Given this list of marker genes WNT7A, EXOC6B, RIPPLY2, TMEM94, KDM6A, SHOX, SH3PXD2B, NLRP1, MYOD1 (NCBI Gene Id 4654), YWHAE, FLVCR2, KCNAB2, SLC26A2, EDEM3, HABP2, PLXNA1, RPS20, CLP1, ENPP1, HUWE1 (HECT, UBA and WWE domain containing E3 ubiquitin protein ligase 1), POLR3A, DHPS, MYH3, CTNND2, TRAPPC9, MAN1B1, TRAF3 (NCBI Gene Id 7187), PIGG, MUSK, CSGALNACT1, KCNJ8, PEX12, PSAT1, CHD7, TOGARAM1, NKX2-1, WDPCP, PPP1CB, SQSTM1, TCOF1, SIX1, DOK7, OBSL1, ANO3, SOS1, PEX26, GATA4, CHRNG, NFIX, TUBB, ZMPSTE24, CREBBP, ATP1A2, CHRND, RPS26, ROBO3, SEMA5A, PALB2, ATP6V1A, IFT74, HDAC8, CFAP418, PTPN6, BBS1, ACTB, ERMARD, GALNS, ANTXR2, TREM2, NELFA, RPL10, MAPT, SGCE, ESAM, PGAP2, SLC25A24, SNRPB, IMPDH2, PTPN22, HPCA, BCOR, MYL11, SUPT16H, THAP1, LETM1, CDH2 (NCBI Gene Id 1000), MSL3, MCTP2 (NCBI Gene Id 55784), TBCK, HNF1B, SCLT1, GDAP2, PIGV, CHRNA1, TGM6 (NCBI Gene Id 343641), DHCR7, SCN2A, RPL35A, RASA2, BUB1B, SPG11, ERCC1, NF1, FBLN5, PUF60, RREB1, ADAT3, ATP7A (NCBI Gene Id 613259), IDH1, SELENON, FZD2, CCDC8, TUBB3, UBE4B, TGFB2, FILIP1, ZNF699, STX16, PLXND1, BMPER, ADA2, CYP27A1, B3GALT6, PCDH19, PSENEN, TUBA1A, DONSON, HIRA, BAP1, SMARCD1, HDAC4, FOXP2, ODC1, KIAA0586, SMARCAL1, ALDH18A1, SPTLC1, SMARCA2, ARHGEF2, BUB3, WNT5A, ALS2, DDX3X, TNNT3, RAB33B, MRPS22, SCN1A, TLR3, AFF3, RYR1, BPTF, ATN1, HEATR3, NAA10, PRMT7 (protein arginine methyltransferase 7), ARSL, GPKOW, MEOX1, IFT43, IGF1R, TUBB4A, KLHL41, RPS24, THPO, LRPPRC, BBS4, RAPSN, CHN1, FANCI, JMJD1C, SMC1A, FLNA, NDUFB10, COG5, ACVR1, ITPR1, AIFM1, ABCC9, COL6A2, UBE2A, TMEM106B, INTU, NAXE, CDK5, RB1 (NCBI Gene Id 92728), CDC42BPB, IL6ST, H4C5, GABRA3, MAP2K1, NUP188, POGZ, PHOX2A, CFL2, PPARG, RIPK4, FTO, SLC39A13, RAB3GAP1, TPM2, GNPTG, LIPE, VPS11, AHDC1, HRAS, MRAS, MKS1, VPS16, MYF5, B3GLCT, ZMYM2, PIGW, SCNM1, RFX7, SPTBN1, BCR, MAPRE2, WAC, NR4A2, MGAT2, GRN, LAMA5, FOXE1, BBIP1, ATRX, SMS, NAA80, TRPV4, TAF1, AEBP1, NEK9, CRLF1, RAF1, TMCO1, TICAM1, ADARB1, SYNGAP1, RAB5IF, RIT1, TWIST1, PHGDH, OTUD6B, NXN (nucleoredoxin), CCN6, CEP290, GP1BB, SMC3, PIGA, DOCK11, POLR1D, DVL1 (NCBI Gene Id 348497), GABRG2, STAG1, TBX5, PIGS, PTPN11, POP1, IGF1, BBS10, POLE, PNKD, RFT1, SNRPN, GNS, FGFR2, BRF1, FBN2, ALDOA, TASP1, RPL15, GABRA1, KNSTRN, WDR37, PDPN, RNU4-2, COL25A1, COL11A2, RAB3GAP2, ALG8, MAN2B1, TBL1XR1, WDR81, SMAD4, PEX6, MMP23B (matrix metallopeptidase 23B), KCNN3, SHOC2, OTUD5, NRAS, RAB23, SLC35A1, PIGO, CANT1, IFT140, BLTP1, MECP2, DCC, RPS28, MYT1L, SPEN (NCBI Gene Id 348488), CLDN11, KCNN2, GNPNAT1, PEX14, PAICS, TRMT10A, CEP55, TAPT1, SF3B2, SCN4A, ACAN, NALCN, ERCC5, PGAP1, PEX16, FANCL, TMEM260, RPS17 (NCBI Gene Id 6218), CNP, PTCH2, GLE1, B4GALT1, PEX13, MRPS28, GJA5, SUFU, CD96, RPL26, AKT1, MEGF8, DRD2, TOR1A, HS2ST1, CCDC22, KMT2B, GLI2, FGFRL1, PIK3CD, PAM16, C2CD3, POLR1C, RMRP, NOTCH3, ATP6V1E1, IRF3, TBX15, PGAP3, ERCC2, SPRED2, FGFR1, DPYD, PIGY, GNE, COG8, BBS5, TBC1D24, NDUFS3 (NCBI Gene Id 4722), FOXC2, SKI, TIMM50, RFC2, EPHB4, GNAL, HPDL, PROP1, CEP57, WWOX, CEP19, KCTD17, HYLS1 (NCBI Gene Id 50957), SOS2, RNU4ATAC, ALG12 (ALG12 alpha-1,6-mannosyltransferase), INPPL1, MEFV, AGPAT2, KCNH1, GATA1, MRPS16, ECEL1, PLAAT3, DDRGK1, PEX10, CASZ1, BBS12, KAT6A, SATB2, HK1, EIF4H, ERCC6, RPL18, LZTFL1, GPX4, EP300, GTF2IRD1, FAM20C, BBS2, CAV1, IDUA, ANKRD11, DLK1, PRDM16, PHLDB1, NBAS, LUZP1, MADD, APC, RPL9, DDC, RRAS, CACNA1A, PEX1, TRAPPC2, PIEZO1, NCF1, SRY, RPS7, LMX1B, NKX3-2, NOG, PCGF2, COL6A1, ESCO2, STXBP1, SCYL2, MAP3K7, LBR, RRAS2, CSPP1, DPYSL5, WASHC5, TRAF7, DVL3, HNRNPK, CAVIN1, BUD23 (BUD23 rRNA methyltransferase and ribosome maturation factor), TRIP11 (NCBI Gene Id 9321), LMOD3, RTL1, NKX6-2 (NCBI Gene Id 84504), FUS, EMD, KMT2A, TSPOAP1, TALDO1, GRIK2, HES7, COG1, TAF6 (TATA-box binding protein associated factor 6), TTN, MPL, TBK1, SEC24C, PEX11B, MYO18B, NOTCH2, LMNA, ASCC3, COX20, MBD5, UNC93B1, RAP1B, TMEM151A, FBXW11, SETBP1, AMMECR1, PIGN, TRPM3, TRIM32, PAFAH1B1, ATP13A2, FGFR3, BRD4, NBN, KIF7, RPS10, ATP6V0A2, DLL3, PSEN1, CDK13, SIN3A, CDH11, CEP85L, TBX2 (NCBI Gene Id 6909), PRKAR1B, CIZ1 (NCBI Gene Id 25792), VAC14, PIGL, RPL35, METTL27, BBS9, CPLX1, WBP11, HBA2, TECPR2, PPP1R15B, SRCAP, TSR2, HSPG2, XYLT1, SALL4 (spalt like transcription factor 4), COL2A1, DYM, EYA1, CTBP1, TBX6, KDM4B, SDCCAG8, GABRD, SEMA3E, SPRED1, MAFB, RPS19, WDR35 (WD repeat domain 35), BRAF, TBP, VPS33A, LZTR1, NIPBL, GPC6, SIX5, SMPD4, SOX9, SCAPER, VPS13D, DNAJC30, HNRNPR, ALDH1A2, NEB, VCP, RPL11, COL11A1, H3-3A, B3GAT3 (NCBI Gene Id 26229), PKDCC, NUP88, SLC35D1, AMER1, XYLT2, DHX37, PRKCZ, INTS1 (NCBI Gene Id 392616), FN1, SLC18A3, ARL6, HESX1, IRX5, PHF8 (PHD finger protein 8), ACTG1, TCTN2, MRPL12, FIG4, VPS35L, FANCB, SLC31A1, RDH11, TRIP13, CUL7, HECTD4, FKBP6, ATP1A3, MED13L, COG7, ITGA7, GLB1, CP, BAZ1B (NCBI Gene Id 9031), SCN9A, USB1, CTCF, RSPRY1, COMT, CBL, EBP, UNC80, CHMP2B, CRKL, EFNB1, GCH1, RPS15A, RPL8, SOX10, FOS, PEX3, ALG9, WNT4, TMEM270 (transmembrane protein 270), ZFX, COL12A1, RAD21, COL6A3, PIK3CA, LHX4, GPC4, FGD1, RPL27, MAGEL2, MAPK1, ERLIN2, STX1A (syntaxin 1A), SLC2A1 (NCBI Gene Id 6513), TBX1, ERI1 (exoribonuclease 1), FAS (Fas cell surface death receptor), ACTA1, NDE1, TXNDC15, HSPA9, FLI1, EXOSC9, IGBP1, SEPTIN9, UFD1, ABCC6, GPC3, GNPTAB, HERC1, ARVCF, RPL5, TTC8, ZNF142, DHCR24, MICU1, SCP2, MED12 (NCBI Gene Id 9968), KCNC3, POFUT1, TBL2, MEG3, TBR1, ROR2, SVIL, KIF26A, ZC4H2, PIK3C2A, MESP2, DKK1, PEPD, FREM2, LFNG, FLNB, VPS37D, VPS51, GNAS, POU1F1, FHL1, MAB21L1, LIMK1, DDR2, GDF6, BSCL2, CDC42 (cell division cycle 42), PEX2, LHX3, POGLUT1, CDK10, FOXF1, GATA2, SCN1B, SIGMAR1, KRT5, GTF2IRD2, CHST3, GUSB, LIFR (NCBI Gene Id 3977), PEX5, PRKRA, PRDX3, RNF170, PTCH1, MYH7, COLEC11, IFT172, MINPP1, MKKS, KRAS, GTF2I, GJA8, PSMD12, GDF3, NSD2, ATP6V1B2, TUBB2B, BUB1, CLIP2, NANS, BBS7, PRRT2, TNNI2, PIEZO2, CNOT3, IFT27, KIF21A, TGDS, IDS, RERE, DOHH, SRRM2, SLC35A2, RPS27, PPP2R5D, MAP2K2, RAB34, CUL4B, NPHP1, ELN (NCBI Gene Id 2006), RPL31, PEX19, TFAP2A, KIF1C, POLR1B, LRP1, KIFBP, KMT2D, TCF4, RPS29, TMEM216, HBA1, here is a description of the gene set: species: Homo sapiens An abnormality of the neck. Abnormality of the neck Human Gene Set: HP_ABNORMALITY_OF_THE_NECK